The following is a description of a gene set: from publication Rock RB, Hu S, Deshpande A, Munir S, May BJ, Baker CA, Peterson PK, Kapur V (PMID 16163375) studied in species Homo sapiens Genes up-regulated in comparison of microglia cells 6 h after stimulation with IFNG versus microglia cells 24 h after the stimulation. Human Gene Set: GSE1432_6H_VS_24H_IFNG_MICROGLIA_UP Microglial cells are resident macrophages in the central nervous system (CNS) and play a pivotal role in the innate and adaptive immune responses against microbial infections. The immune functions of microglia are regulated by a milieu of cytokines including interferon (IFN)-gamma. We here performed a series of experiments to acertain the transcriptional profile of human fetal microglial cells at 1, 6, and 24 h after IFN-gamma treatment. Primary human microglial cells were either untreated or treated with 200u/ml IFN-gamma. Affymetrix U133A chips were utilized. Four different tissue samples (B18, O, W, and Y20) were analyzed at the three time points., and this is the list of marker genes: HEG1, TNPO3, DVL3, EMP3, ACTR10, PLSCR1, MMP19, COL6A1, BCAP29, MAP3K6, ANKRD6, PWP1, STAB1, SWAP70 (switching B cell complex subunit SWAP70, NCBI Gene Id 23075), RAB5B, PAFAH1B1, RAMP1, CBLL1, PLEKHM2, SLC27A2 (solute carrier family 27 member 2), ESD, OLR1, ZNF654, GABPB1, CLIC1, HTRA2, GNG12, IL1R1, AKIRIN1, PAPSS2, MX1, EIF5B, AGO3, RBBP8, SSB, ITGB3, ATP6V1C1, SDS, SCD, NBPF10, FLNA, FERMT2, ADRA2C, AMD1, NOP16, TAF9, KIDINS220, PKD2L2, EXT2, TARDBP, ANXA2, TGFA, SAP30BP, BBC3, CHST7, RAD23A, CYP1B1, THOC2, RSAD2, STAU1, MOB3B, FCGR2B, ARMC9, SPTBN1, ANXA2P2, MELK, MAST2, LARGE1, IL3RA, GDI2, SDC2, AKT3, KIAA0753, P2RX4, SYPL1, TMEM185B, IL4R, SH2B3 (NCBI Gene Id 10019), PHLPP1, GSPT1 (G1 to S phase transition 1), PTDSS2, CD14, GPNMB, B3GALNT1, LGALS1, CGGBP1, RALA, RHOG (NCBI Gene Id 391), CADM1, APOBR, GPR37, YIPF4, SNX15, GPR161, ADAR, TDRD7, PDE2A, VEZF1, SMARCA1, FBXO31, TBC1D29P, MARK2, GSTM3, PPP2R5B, ARG2, PPP4R1, HK1, RNF24, GAPDH, OPN3, PPIA, ERBIN, MARCHF5, EP300, CDKN2AIP, IL7R, SFPQ, MRC1, PODXL, SPTSSA, KIAA0040, GK, YWHAZ, KRT10, PANX1, SH3BP2, SAR1A, CYP1A1, GARS1, DNAJC8, HUS1, PMF1, S100A3, DSC2, NECTIN3, SERINC1, ACTR1A, MPDZ, MMP2, UBE2E3, CEMIP2, COX7A1, SRC, SLC25A44, DCTN2, UNC13B, SEMA6B, TOP1, PTBP3, MFHAS1, USB1, MLF1, EIF1, MED21, CACFD1, SIPA1L1, PDGFC, TYMS, HRAS, TRIP12, SULF1 (sulfatase 1), SNCA, IQGAP1, PITPNC1, NRP2, SPARC, PIMREG, ITCH, CDIPT, FLOT1, CERS2, DYRK3, CDC27, MARCHF6, FOLR2, TARS1, CELSR1, PHACTR1, SMS, CD9, S100A10, VGLL3, NECTIN2, SSBP2, S100A9, STAT3, CTNNA1, TLE4, TRNAU1AP, TRIM25, RAB8B, IL1R2, PITPNB, IGFBP7, CD163, FCGR2A, HS3ST2, UEVLD, LMNA, TPRA1 (transmembrane protein adipocyte associated 1)